The following is a description of a gene set: part of: Insulin receptor signalling cascade This event has been computationally inferred from an event that has been demonstrated in another species.<p>The inference is based on the homology mapping from PANTHER. Briefly, reactions for which all involved PhysicalEntities (in input, output and catalyst) have a mapped orthologue/paralogue (for complexes at least 75% of components must have a mapping) are inferred to the other species. electronically inferred by orthology from the curated human pathway Reactome Pathway: IRS activation species: Mus musculus, and this is the list of marker genes: Ins1, Irs1, Ins2, Irs2